Given this list of marker genes Cnnm2, Ptpn11, Ivns1abp, Lin9, Tnfsf4, Panx3, Nlk, Heca, Rps6ka2, Pcdh15, Stk4, Napg, Nectin3, Atg9b, Adipor1, Qki, Irf2bp2, Esm1, Wapl, Eea1, Dpp10, Psg18, Slc45a3, Etl4, Slc25a46, Glul, Cog2, Papolg, Ncaph2, Vezf1, Fmo9, Nr4a3, Ntrk3, Sertad2, Nefm, Prpf18, Ablim2, Arfip1, Dsg3, Nefl, Rhot1 (NCBI Gene Id 80692), Fli1, Tomm22, Satb1, Dpf3, Zfp644, Ptbp2, Mafk, Defb4, Hmgn5, Cobl, Uvssa, Ube3a, Psg29, Car2, Cfap97d2, Gnrhr, Comtd1, Dph3, Hgs, Llgl1, Ywhaq, Acadsb, Marveld3, Mafg (NCBI Gene Id 319360), Fbxl2, Dsg2, Or52n4, Sln, here is a description of the gene set: Genes predicted to be targets of miRBase v22 microRNA mmu_miR_7094_3p in miRDB v6.0 with MirTarget v4 prediction scores > 80 (high confidence targets). from publication Chen Y, Wang X (PMID 31504780) species: Mus musculus Mouse Gene Set: MIR_7094_3P